The following is a description of a gene set: species: Homo sapiens Human Gene Set: HP_PERIVENTRICULAR_CYSTS Periventricular cysts, and this is the list of marker genes: ODC1, PDHB, PLAA, FBXL4, UQCC3, LETM1, LIPT2, ESAM, PDHX, CTBP1, FARSA, GFAP, FGFRL1, OCRL, NSD2, CPLX1